The following is a description of a gene set: Genes predicted to be targets of miRBase v22 microRNA mmu_miR_201_3p in miRDB v6.0 with MirTarget v4 prediction scores > 80 (high confidence targets). Mouse Gene Set: MIR_201_3P from publication Chen Y, Wang X (PMID 31504780) studied in species Mus musculus, and this is the list of marker genes: Zfp189, Tktl2, Rlig1, Zswim6, Kcna1, Cfap300, Cnr1, Garnl3, Gsk3b, Magea9, Tent4b, Scaper, Rhno1, Khdrbs3 (NCBI Gene Id 13992), Rasa1, Camk4, Pik3ca, Rbm6, Neb, Zbtb33, Neurod1, Snhg11, Myt1l, Insyn2a, Mcc, Map2k5, Rnf135, Larp4b, Rab8b, Rbm8a, Akr1d1, N4bp1, Cldn12, Pcdh20, Insm2, Synj2, Rbmyf6, Btg2, Megf11, Trafd1, Rbmyf3, Abcd3, Pnn, Rock1, Tfpi2, Ddx5, Kcnd3, Dcbld2, Spata13, Sfi1, Nfe2l2, Dennd5a, Tm4sf1, Yaf2, Snx27, Vapa, Gabra5, Gls, Ypel2, Cpb1, Inpp4a, Smim1, Mark1, Slc29a2, Steap4, Phf11d, Creb5, Mybl1, Pcbp2, Pcdh18, Dedd, Tmem185b, Hivep1, Rbmyf5, Smpdl3a, Jarid2, Abraxas1 (NCBI Gene Id 71440), Ube2g1, Ptbp2, Sorcs3, Slc16a4, Ascl1, Dusp11, Klhdc10, Cav2, Csde1, Rbmyf8, Slc8a1, Pcdh17, Taf7l2, Ammecr1l, Evl, Atxn1, Slc30a6 (solute carrier family 30 (zinc transporter), member 6), Atp13a5, Luc7l3, Prkaa2, Tcf12, Cmah, Tmem43, Lypla1 (NCBI Gene Id 18777), Rbmy, Slc4a5, Atp1b4, Rbmyf9, Rnf146, Ube2d3, Hs6st2, Rimklb, Gch1, Cebpz, Cadps, Cd247, Rbmyf1, Plscr1, Epc1, Tbc1d1, Tpbg, Rbmyf7, Magt1, Stradb, Capsl, Manea, Arih1, Ifi204, Rbmyf2